Given this list of marker genes Lgals1, Dnajb1, Ap4s1 (NCBI Gene Id 11782), Akr1b8, Hopx, Retn, Xrn2, Spin1, Lipe, Tshr, Nt5e, Ifi203, Krt17, Prkacb, Rptn, Cd36, Ctbs, Opa1, Hoxb2, Scaf11, Swsap1, Krtdap, Atm, Akr1c18, Pecam1, Man1a2 (NCBI Gene Id 99756), Fscn1, Kdm8, Rbbp6, Tcf20, Dlx1, Foxp1 (NCBI Gene Id 73231), Rab2b, Hbp1, Serpina12, Celf2, Car3, Stom, Ltc4s, Rbms1, Nav2, St3gal2, Hcar2, Skp2, Arxes1, Pdlim5, Rgs4, Art1, Arpp19, Incenp, Dnm2, Rnf14, Cldn15, Amd-ps1, H2-Aa, Sh3rf1, Phb2, Serpinb2, Vps25, Piwil2, Gstz1, Pon3, Ctdsp2, Ip6k1, Lims1, Inppl1, Uqcrb, Fbln1, Hmga1, Tg, Ptprg, Mef2a, Ddr1, Hmgb1, Mt2, Dnajc17, Apoa4, Arcn1, Tnfsf14, Wars1, Stard4, Mis12, Clcf1, Mob1a, Map3k5, Polr3a, Agk, Gabrp, Pitpnb, Casq1 (NCBI Gene Id 12372), Car4, Arxes2, Etfdh, Gosr2, Pck1, Pcyt1a, Papola, Add3, Capzb, Cx3cr1, Cfap97, Tcf7 (transcription factor 7, T cell specific), Prelp, Nabp1, Mki67, Sox5, Ilf3, Hspb7, Ranbp9, Prmt6, Pdk4, Zfp445, Chd9, Ndufa2, Chpt1, Epha5, Bhlha15, Ucp3, Actb, Hhip, Col1a1, Rab40c, Gclc, Wdr45, Tubgcp2, Scube1, Lep, Pfkfb3, Zfp36, Pgd, Cyp17a1, Cmtr1, Sult2b1, Rtn4, Cd59a, Dram1, Il6st, Add1, Cat, Cdkn1a, Misp, Nedd4, Aco1, Map2, Prkd3, Enc1, Rabgap1, Mtf2, Snrpn, Rhov, Mrpl39 (NCBI Gene Id 54134), Septin8, Sprr2a1, Hmga2 (NCBI Gene Id 77357), Ces4a, Pex13, Pld1, Hbs1l, Cacna2d1, Pcsk6, Slc39a3, Rbm6, Cfl2 (cofilin 2, muscle), Chchd10, Tm6sf2, Gsk3b, Shmt1, Mr1, Ube2h, Sigmar1, Cebpg, Rrad, Clcn3, Cryba4, Yipf4, Lgals7, Slc25a10, Dpysl3, Acsl1, Plin4, Cct2, Egfr, Tgfbr3, Tmem45a, Nit2, Bach1, Camkk2, Rarg, Hr, Hcfc1, Nsf, Tbrg4, Eri2, Hacd2, Os9, Rhog, Hspa9 (heat shock protein 9), Fabp1, Pmel, Tmod2, Aurkc, Ereg, Cd44, Smad5, Ropn1l, Tcap, Pja1, Agpat1, Tslp, Rnf114, H2-D1, Mgll, Srpk1, Baalc, Apba3, Snx30, Klb, Xist, Itih5, Col6a2 (collagen, type VI, alpha 2), Hipk3, Casp6, Angptl2, Arl5a, Psme4, Cenpv, Dmd, Dnajc3, Ephx1, Lsm12, Shisa2, Lcp1, Ap3m1, Ptgs2, Tcim, Gbp2, Nsun4, Msh4, Cpt1b, Nhsl1 (NCBI Gene Id 70502), Prps1, Gm13394, Cwh43, Tecr, Osr2, Art3, Car13, Camk4, Hif3a, Fads2, Rfc1, Ctsb, Riok2, Ypel1, Lrg1, Masp1, Ldhc, Sprr1b, Ccdc71, Cenpb, Cp, Aqp1, Ovol1, Erc1, Alas1, Fgfr2, Ak3, Mrc2, Brat1, Calhm5, Lgals9, Golga4, Itgav, Itm2a, Ckm, Pdap1, Pabpn1 (NCBI Gene Id 54358), Igf2, Ints12, Lgals3bp, Slc22a21 (solute carrier family 22 (organic cation transporter), member 21), Il1r2, Eif4ebp1, Rrm1, Ammecr1l, Riok3, Krt77, Trex2, Ptpre, Map1b, Krt79, Pcolce, Tcf12, Rpn2, Asph, Ubap2l, Pde4dip, Tpsab1, Wdr12, Zfp574, Gm12617, Tes3-ps, Sf3b2, Scd2, Plcb1 (phospholipase C, beta 1), Sncg, Tmcc3, Elovl6, Ncf2, Rcc2, Aatf (NCBI Gene Id 80585), Fryl, 1810037I17Rik, Ggt1, Herc6 (hect domain and RLD 6), Nlk, Bmp1, Get3, Ccnl1, Caprin1, Thrap3, Lmnb1, Itga9, Tspo, Mcm6, Ubqln4, Hacd3, Cfd, Wdr48, Fech, Rab12, Krt75, Ryr1, Hdlbp, Ptpn13, App, Rasl11b (NCBI Gene Id 68939), Gjb6, Fads3, Cryl1, Sod3, Prkar1b, Krtcap2, Twsg1, Spesp1, Acsl5, Sh3kbp1, Rgcc, Cap1, Pbk, Btc, Spag5, Cav2, Sgpl1, Actrt2, Bach2 (BTB and CNC homology, basic leucine zipper transcription factor 2), Star, Iigp1 (interferon inducible GTPase 1), Siah1a, Tenm4, Avpr1a, Ly6d, Slc48a1, Cldn11, Errfi1, D17H6S56E-5, Abcc5, Lrrc8c, Gnas, Myo5b, BC028528, Mt1, Abca2, Ide, Ccnl2, Timp3, H2-K1, Msra, Nubp1, Thbs1, Tmem234, Ncf1, Qsox1, Tmem131l, Kras, Gja1, Tgs1, Mif4gd, Purb, Clns1a, Eif4g1, Cldn10, Extl3, Fgfbp1, Gpd1, Txnip, Aif1l, Grk4, Slc39a11, Rad21, Tceal6, Nap1l1, Crim1, Sorbs1, Slc11a2, Rmnd5b, S100a10 (NCBI Gene Id 99776), Pnpla2, Plek2, Cars1, Slc25a13, Ceacam1, Ctr9, Sprr2d, Serp1, Bzw1, Mst1r, Cald1, Bcl2l13, Pigb, Fbp2, Babam2, Atpaf2, Krt12, Man2b1, Arhgap1, Mga, Fut2, Abcb8, Clk1, Kif20a, Ank3, Cpd, Glrx, Myh1, Pou2f3, Atxn7l3b, Mrap, Nr3c1 (nuclear receptor subfamily 3, group C, member 1), Rpl3l, Plk1, Pmfbp1, Chrnd, Lancl2, Brd2, Lyz2, Spon1, Esyt3, Eloc, G6pdx, Slc25a30 (solute carrier family 25, member 30), Ykt6, Apoc2, Racgap1, Trf, Cab39l, Slc25a48, Rarres2, Ube2d3, Slc5a6, Ndufaf7, Cdc42bpa, Mir214, Tpp2 (tripeptidyl peptidase II), Suco, Eml5, Cux1, Col4a5, Dram2, Sf3a2, Cidec, Hoxa9, ENSMUSG00000139502, Fuca1, Rpa1, Ephx2, Zfp260, Serpinf1, Atp2a1, Cyp4b1, Hnf4g, Foxc1, Rab31, Cdh3, Il2rg, ENSMUSG00000125611, Fam107b, Wwc1, Abce1, Acox1, Pkig, Myh6, Coa5, Slc35a2, Ncapd2, Rbp7, Lum (lumican), Usf1, Tfrc, Smad1, Plec, Sprr1a, Psap, Serinc3, Ikzf1, Wnt5a, Gna13, Taok1, Neurod4, Ncoa4, Cysrt1, Hoxb6, Ubl5, Dusp1, Pla2g2f, Srrm1, Frmd4b, Nr4a1, Adgrg1, Zfr, Bad, Cer1, Timp1, Idh3g, Zfp148, Ntn1 (NCBI Gene Id 276903), Cldn5, Sgcg, Ccl9, Trbv29, Il36g, Ptprf, Sox9, Ptgfr, Trp63, Cers4, Junb, Zc3h11a, Fah, Fkbpl, Tpo, Rbbp4, Pmepa1, Strbp, Ifi27l2a, Il36a, Trp53, Immt, Hmgcs2, C1d, Tfdp1, Fabp4, Klf3, Ptbp3 (NCBI Gene Id 99962), Adipoq, Gdpd3, Pum1 (NCBI Gene Id 80912), Ccnd1, Nnat, Krt85, Dynlt1b, ENSMUSG00000144058 (novel transcript), Scoc, Jak1, Recql, Rxra, Snca, Nme7, Myl1, Ndufa5, Sptbn1, Mgat2, Ptpn14, Gip, Ier3, Lpin1, Kat7, Dgcr2 (NCBI Gene Id 13356), Pira1, Thrsp, Pcx, Smarca4, Peg3, Nkd2, Zmynd11, Ddx3x, Lasp1, Mrpl3, Krt36, Zdhhc5, Gzmg, Ppp4r3b (NCBI Gene Id 104674), Slc35a3, Wrn, Grb10, Fth1, Dnph1, Srek1ip1, Pcca, Safb2, Snrpg, Rdh11, Rab6a, Pkdrej, Slc2a4, Cenpa, Mfap5, Fbln2, Sec61a2, Sar1a, Ndufa3, Retnlb, Pde3a, Usp34, Rnf41, Elovl3, Kif11, Gpsm1, Krt16, Rpl23, Aplp2, Bid, Asb7 (ankyrin repeat and SOCS box-containing 7), Ubc, Ethe1, Bmerb1, Trip13, Cav3, Bcap31, Ppp3ca, Sprr2h (NCBI Gene Id 99694), 5033421B08Rik, Ccnd2 (NCBI Gene Id 97325), Laptm4a, Chd4 (chromodomain helicase DNA binding protein 4), Bnip3, Iapp, Gna12, Eif4h, Hipk2, Washc2, Actn3, Sirpa, Hadh, Ghr, Pink1, Ccn1, Wee1, Tnfrsf19, Vamp8, Acbd3, Ucp2, Lman1, Hjurp, Lpl, Qng1, Usp18, Ublcp1, Acta1, Atf2, Dlx3, Stx18, Fgf7, Sox4 (SRY (sex determining region Y)-box 4), Srek1, Qki, Tpr, Rassf3, Tmem106b, Emp2, C1qb, Glo1, Ccl20, Fgl2, Clca3a1, Sdcbp2, Tgfbr2, Rtp4, Efnb1, Il36rn, Tcea1, Acaa2, Rbfox2, Pdpk1, Ero1a, Neu2, Sap18, Ctns, Lgr5, Uck1, Capn6, Prmt5, Camk2b, Eif3a, Cep85, Zfp106, Pds5a, Cd74, Xdh, Fhl2, here is a description of the gene set: species: Mus musculus Genes up-regulated in mice with skin specific knockout of RB1 by Cre-lox. Mouse Gene Set: MARTINEZ_RB1_TARGETS_UP Squamous cell carcinomas (SCC) represent the most aggressive type of nonmelanoma skin cancer. Although little is known about the causal alterations of SCCs, in organ-transplanted patients the E7 and E6 oncogenes of human papillomavirus, targeting the p53- and pRb-dependent pathways, have been widely involved. Here, we report the functional consequences of the simultaneous elimination of Trp53 and retinoblastoma (Rb) genes in epidermis using Cre-loxP system. Loss of p53, but not pRb, produces spontaneous tumor development, indicating that p53 is the predominant tumor suppressor acting in mouse epidermis. Although the simultaneous inactivation of pRb and p53 does not aggravate the phenotype observed in Rb-deficient epidermis in terms of proliferation and/or differentiation, spontaneous SCC development is severely accelerated in doubly deficient mice. The tumors are aggressive and undifferentiated and display a hair follicle origin. Detailed analysis indicates that the acceleration is mediated by premature activation of the epidermal growth factor receptor/Akt pathway, resulting in increased proliferation in normal and dysplastic hair follicles and augmented tumor angiogenesis. The molecular characteristics of this model provide valuable tools to understand epidermal tumor formation and may ultimately contribute to the development of therapies for the treatment of aggressive squamous cancer. from publication Martínez-Cruz AB, Santos M, Lara MF, Segrelles C, Ruiz S, Moral M, Lorz C, García-Escudero R, Paramio JM (PMID 18245467)